The following is a description of a gene set: studied in species Homo sapiens Neighborhood of CDC20 Human Gene Set: GNF2_CDC20 Neighborhood of CDC20 CDC20 cell division cycle 20 homolog (S. cerevisiae) in the GNF2 expression compendium, and this is the list of marker genes: KIF2C, RRM1, AURKB (aurora kinase B), FOXM1, CDCA8, HMMR, CDK1, TPX2, RAN, RRM2, PTTG1, CKS2, CDCA3, ESPL1, CCNB2, SMC2, NSD2, CENPE, CDC20, BUB1 (NCBI Gene Id 699), CCNA2, PLK1, CKS1B, KIF4A, AURKA, BUB1B, H2AX, BIRC5, NCAPH, MCM4, KIF11 (NCBI Gene Id 3832), MT1JP, MKI67 (NCBI Gene Id 4288), UBE2C, TOP2A, UBE2S, ZWINT, TTK, TYMS, SPAG5, MCM2, NDC80, GMNN, SMC4, KIF20A, DLGAP5, KIF18B, CENPF, ASPM, SHCBP1, PLK4, PCNA, RACGAP1, MELK, PRC1, NUSAP1